The following is a description of a gene set: studied in species Mus musculus The process in which the anatomical structures of a limb joint are generated and organized. A limb joint is a flexible region that separates the rigid sections of a limb to allow movement in a controlled manner. Mouse Gene Set: GOBP_LIMB_JOINT_MORPHOGENESIS, and this is the list of marker genes: Col3a1, Sulf1, Osr1, Errfi1, Col6a1, Ctnnb1, Ext1, Osr2